The following is a description of a gene set: Mouse Gene Set: WP_ACE_INHIBITOR_PATHWAY species: Mus musculus ACE inhibitor pathway, and this is the list of marker genes: Kng1, Ace, Agtr2, Ren1, Agt, Nos3, Bdkrb2, Agtr1a